Given this list of marker genes TENT4B, MTPAP, TENT5D, TENT5A, TENT5B, PAPOLB, PAPOLG, TUT1, TENT4A, TENT5C, PAPOLA, TENT2, here is a description of the gene set: species: Homo sapiens Catalysis of the reaction: ATP + RNA(n) = diphosphate + RNA(n)-3'-adenine ribonucleotide. The primer may be an RNA or DNA fragment, or oligo(A) bearing a 3'-OH terminal group. Human Gene Set: GOMF_POLY_A_RNA_POLYMERASE_ACTIVITY